The following is a description of a gene set: Human Gene Set: GSE29618_MONOCYTE_VS_MDC_UP from publication Nakaya HI, Wrammert J, Lee EK, Racioppi L, Marie-Kunze S, Haining WN, Means AR, Kasturi SP, Khan N, Li GM, McCausland M, Kanchan V, Kokko KE, Li S, Elbein R, Mehta AK, Aderem A, Subbarao K, Ahmed R, Pulendran B (PMID 21743478) Systems vaccinology has emerged as an interdisciplinary field that combines systems wide measurements and network and predictive modeling applied to vaccinology. Here we used the systems vaccinology approach to study the molecular mechanisms underlying th studied in species Homo sapiens Genes up-regulated in comparison of monocytes versus myeloid dendritic cells (mDC)., and this is the list of marker genes: NPC2, VCAN, CDA, FUT4, UBE2D1, TBC1D8, SLC22A4 (NCBI Gene Id 6583), FCN1, EGR2, ABHD5 (NCBI Gene Id 51099), GLUL, NFKBIA, CEBPB, HIF1A, LILRA6, GASK1B, FRY, MARCO, ATXN1, TCF7L2, CD46, S100A4, TMEM127, RXRA, USP3, RAB5IF, FBN2, APOBEC3A, EIF1, IFNGR2, DMXL2, CR1, HCAR3, PLA2G7, EXT1, NPL, CCR1, CYBB, LILRA3, SULT1A2, AOAH, ELL2, IER3, CD44, CYP27A1, BLVRA, LDLR, BCL2A1, SMARCD3, MPP1, CALML4, BTG2, MPO, FGR, PTGER2 (NCBI Gene Id 63381), CTSS, BEST1, CD68, GNS, CD163, S100A9, C5AR1, CD36, CD63, CTSL, CTSD, CPD, ATP6AP2, ITM2B, SDCBP, CTSB, FCAR, SEMA4D, DUSP6, TNFSF13, ADM, KIAA0513, LIN7A, NLRP3, KLF7, MIR22HG, SLC11A1, PDE6H, TNFRSF1B, HNMT, RIN2, CREG1, NACC2, ADIPOR1, PELI1, HMOX1, UPP1, TYROBP, MAP4K4, MBD2, BNIP3L, LAMP1, FCER1G, CLMN, TREM1, STS, SLCO3A1, RBMS1, IFFO1, DRAM1, CFD, CD93, VPS37C, CRISPLD2, IRAK3, APLP2, FPR1, SIRPB1, NCF1C, GRK6, CYP1B1, PIK3IP1, PGD, PNPLA2, PILRA, OAS1, SPRY4, G0S2, RIT1, IL15, HLA-B, SLC7A7, S100A8, ABCA1, MAFB (NCBI Gene Id 9935), SCPEP1, TKT (transketolase), BST1, SORL1, TIAM1, SDF2, FYB1, VNN2, MKNK1 (MAPK interacting serine/threonine kinase 1), TUBA4A, RCBTB2, PSAP, ARHGEF40, HPSE, CSF3R, SOD2, FXYD6, FCGR2A, EVI2A, LILRB3, CDC42EP3, SERPINA1, MTARC1, MAP3K7CL, CKAP4, NCF2, MARCKS, CXCL8, QPCT, ARHGEF10L, BACH1, IRS2, ZDHHC7 (zinc finger DHHC-type palmitoyltransferase 7), FBXL5, PLAGL2, LILRA2, LILRB1, GAB2, PYGL, NINJ1, SLC31A2, CXCL2, FTL, ASAH1, NOTCH2, ITGAM, TLR4, ACSL1 (NCBI Gene Id 91249), PDXK, IFI30, RNF19B, ALDH1A1, EGR1, LRP1, CD14, AIF1, GIMAP5, GMFG, HLA-F, IGF2R, CHST15, MXI1, RTN3, F5 (NCBI Gene Id 98271), S100A12, BIN2, NAMPT, ADGRE1, LTA4H, WLS